The following is a description of a gene set: Mouse Gene Set: WP_GLYCOGEN_METABOLISM Glycogen metabolism species: Mus musculus, and this is the list of marker genes: Ppp2r5b, Phkg2, Gbe1 (NCBI Gene Id 74185), Ppp2r2c, Gyg1, Pygl, Ppp2ca, Ppp2r2b, Gys2, Pygb, Ugp2, Pygm, Ppp2r5c, Ppp2r5e, Phkb, Gsk3a, Ptpa, Ppp2r3a, Gys1, Ppp2r1a, Calm1, Ppp2r2a, Ppp2r1b, Agl, Phka1, Calm3, Gsk3b, Ppp2r5d, Ppp2r5a, Phka2, Pgm1, Calm2, Phkg1 (phosphorylase kinase gamma 1), Ppp2cb